The following is a description of a gene set: The presence of an altered number of the incisor teeth. species: Homo sapiens Abnormal number of incisors Human Gene Set: HP_ABNORMAL_NUMBER_OF_INCISORS, and this is the list of marker genes: STAG2, SMAD2, ERCC3, EIF4A3, PAX9, WNT10B, DLG1, PDGFRA, CDON, DISP1, NHS, DLX4, CRIPTO, ARHGAP29, EVC2, LRP6, PLCH1, NEK1, SHH (NCBI Gene Id 6469), AXIN2, FOXH1, ARHGEF38, WNT10A, MID1, ADAMTS15, IRF6, EDA, PTCH1, SUFU, DLL1, ANKRD11, SMC1A, B3GLCT, BCOR, SIX3, NAA10, RIC1, FGFR1, TP63, ZIC2, CDH1, CDC42BPB, STIL, EDARADD, CDH11, GLI2, TGFA, RIPK4, MSX1, GAS1, DLX3, NODAL, SUMO1, COBLL1, BLM, CNOT1, TGIF1, BMP4, FGF8, EVC, NECTIN1